Given this list of marker genes Adcy7, Prkaca, Camkk1, Prkca, Prkcg, Prkar2b, Pde1b, Prkar1b, Camkk2, Adcy8, Prkacb, Adcy5, Pde1c, Calm1, here is a description of the gene set: part of: Ca-dependent events; DAG and IP3 signaling Reactome Pathway: CaM pathway studied in species Mus musculus electronically inferred by orthology from the curated human pathway This event has been computationally inferred from an event that has been demonstrated in another species.<p>The inference is based on the homology mapping from PANTHER. Briefly, reactions for which all involved PhysicalEntities (in input, output and catalyst) have a mapped orthologue/paralogue (for complexes at least 75% of components must have a mapping) are inferred to the other species.